Given this list of marker genes ANKS6, NUP133, WT1, OSGEP, NUP37, TMEM126B, ALMS1, SEC61A1, CEP290, SMARCAL1, NUP107, EMP2, RNU7-1 (NCBI Gene Id 100147744), MAPKBP1, CFHR5, JAG1, CPT2, NUP160, NOD2, SPRY2, YRDC (yrdC N6-threonylcarbamoyltransferase domain containing), RRM2B, GAPVD1, LAMA5, MEFV (MEFV innate immunity regulator, pyrin), NPHP1, PLCE1, COQ6 (coenzyme Q6, monooxygenase), COL4A3, SGPL1, CD2AP (NCBI Gene Id 25916), BBIP1, APOA1, PTPRO, LZTFL1, NUP205, CD81, SLC7A7, DGKE, TBC1D8B, NPHS2, IFNG, CLDN19, SLC37A4, ROBO1, NUP93, RPGRIP1L, APRT, MMUT, C3, AGXT, MYOCD, LAMB2, COL4A6, TPRKB, MAFB, DZIP1L, IFT43, CEP164, TTC21B, UMOD, COQ8B, SLC41A1, ZMPSTE24, COL4A4, AVIL, EHHADH, GANAB (glucosidase II alpha subunit), SRCAP, DCDC2, NEK8, CTNS, TRAF3IP1, APOL1, DSTYK, OCRL, FN1, TRPC6, PKD1, GON7, CLCNKA, NPHP4, NPHS1, BNC2 (basonuclin zinc finger protein 2, NCBI Gene Id 54796), RAD51C, SDCCAG8, GATM, LMX1B (NCBI Gene Id 4010), TP53RK, CLCN5, MAGI2, CLDN16, COL4A5, LYZ, IFT56, LAGE3, HNF1B, ACTN4, CLCNKB, TSC2, CEP83, SLC34A1, ARHGAP24, GSN, ANLN, FAN1, PKHD1, PAX2, PRKCD, BICC1, DAAM2, CRB2, ANKFY1, NOS1AP, TMEM67, ARHGDIA, NUP85, INVS, ALG9, MYO1E, CC2D2A, IFT122, WDR19, NPHP3, INF2, XPNPEP3, PKD2, IFT140, BSND, CD151, TSC1, GLIS2, DNAJB11 (DnaJ heat shock protein family (Hsp40) member B11), AHI1 (Abelson helper integration site 1), MUC1, IQCB1, NDUFAF6, ALG5, here is a description of the gene set: species: Homo sapiens Stage 5 chronic kidney disease Human Gene Set: HP_STAGE_5_CHRONIC_KIDNEY_DISEASE A degree of kidney failure severe enough to require dialysis or kidney transplantation for survival characterized by a severe reduction in glomerular filtration rate (less than 15 ml/min/1.73 m2) and other manifestations including increased serum creatinine.